The following is a description of a gene set: from publication Burton GR, Nagarajan R, Peterson CA, McGehee RE Jr (PMID 15033539) Strongly down-regulated at 8-48 h during differentiation of 3T3-L1 cells (fibroblast) into adipocytes. species: Mus musculus During cellular differentiation and development, it is recognized that many complex molecular mechanisms as well as precise patterns of differentially expressed genes occur in directing precursor cells toward a given lineage. Using microarray-based technology, we examined gene expression across the course of 3T3-L1 adipocyte differentiation. Total cellular RNA was isolated at times 0, 2, 8, 16, 24, 48, and 96 h following treatment with either standard hormonal inducers of differentiation; insulin, dexamethasone, isobutylmethylxanthine (IDX), or IDX plus trichostatin A (TsA), a histone deacetylase inhibitor and potent adipogenic inhibitor. cRNA was synthesized from cellular RNA and hybridized to high density Affymetrix MG_U74Av2 microarray gene chips containing 12,488 cDNA/Expressed Sequence Tags (ESTs) probe sets. From the IDX-only treated cells, all probe sets that were either unchanged or differentially expressed less than 2-fold throughout differentiation with respect to time 0 preadipocytes were excluded from further analyses. This selection resulted in a net of 1686 transcripts, 859 were increased in expression, and 827 were decreased in expression at least 2-fold across differentiation. To focus in on genes that were more specific to differentiation, the same analysis was performed on IDX plus TsA-treated non-differentiating cells and all probe sets from the IDX-only group that exhibited similar expression profiles in the non-differentiating TsA-treated group were excluded leaving a total of 1016 transcripts that were regulated only under differentiating conditions. Six hundred and thirty-six of these transcripts were elevated at least 2-fold and 380 exhibited a decrease in expression relative to time 0 preadipocytes. This group of genes was further analyzed using hierarchical clustering and self-organizing maps and resulted in the identification of numerous genes not previously known to be regulated during adipocyte differentiation. Many of these genes may well represent novel adipogenic mediators and markers of adipogenesis. Human Gene Set: BURTON_ADIPOGENESIS_10, and this is the list of marker genes: MTM1, LPL, NOL7, CETN2, FLOT1, ACADL, ATP6V1C1, MSMO1, VCL, FDFT1, RAB3IL1, DOCK9, FDPS, NSDHL, HMGCS1, CPEB2, SQLE, SEPTIN10, SOWAHC, UBA3, TMEM37, CCNG2, FAM107B, CAVIN2, PKP2, ZFAND6, STRBP, ANXA6, LRRFIP1, GYG1, PYGB